Given this list of marker genes Ppp2cb, Per1, Gstp2 (NCBI Gene Id 269054), Klf9, Azin1, Dazap2, Cebpb, Pigf, Gfra1, H2-DMa, Qki, Nckap1, Bmal1, Ugp2, Cry2, Pura, Erc2, Per2, Psma4, Dnaja1, Stbd1, Sf3a3, Sumo3, Idi1, Sumo1, Ncoa4 (nuclear receptor coactivator 4), Tubb4a, Zfr, Hspa8, Clock, Nr1d2, Cbx3, Myf6, Eif4g2, Gstm3, Etv6, Tob1 (NCBI Gene Id 22057), G0s2 (NCBI Gene Id 98617), Nr1d1, Btg1, Cldn5, H2bc15, Vapa, Cry1, Rbpms, Herpud1, Ucp3, Tab2, Ppp1r3c, here is a description of the gene set: species: Mus musculus Exercise-induced circadian regulation Mouse Gene Set: WP_EXERCISEINDUCED_CIRCADIAN_REGULATION